Given this list of marker genes IFIH1, TRIM27, APOBEC3D, APOBEC3A, ARK2N, TRIM6, BTBD17, IFITM2, ISG20, PPIA, SRPK2, IFNB1, TRIM14, RSAD2, FAM111A, OAS1, HEXIM1, TRIM8, ZFP36, APOBEC3F, OAS2, ZNFX1 (zinc finger NFX1-type containing 1), IFITM1, AICDA, TRIM31, TRIM62, IFI16, ISG15, PROX1, MBL2, SP100, TNF, CCL5, SLPI, APCS, OASL, IFIT5, TRIM21 (NCBI Gene Id 6737), MID2, IL32, MX1, PLSCR1, APOBEC3H (NCBI Gene Id 164668), PTX3, VAPB (VAMP associated protein B and C), APOBEC3C, OAS3, APOBEC3G, SRPK1, TNIP1, TRIM11, TRIM28, EIF2AK2, IFITM3, LARP7, RNASEL, ZC3HAV1, STAT1, UBP1, ILF3 (interleukin enhancer binding factor 3), N4BP1, BANF1, HMGA2, TRIM32, IFNL3, INPP5K, LTF, IFIT1, CSNK2B, BST2, SHFL, APOBEC3B, TRIM13, CH25H, TRIM15, MAVS, here is a description of the gene set: Human Gene Set: GOBP_NEGATIVE_REGULATION_OF_VIRAL_PROCESS species: Homo sapiens Any process that stops, prevents, or reduces the frequency, rate or extent of a multi-organism process in which a virus is a participant.